The following is a description of a gene set: Mouse Gene Set: GOBP_PEROXISOME_FISSION species: Mus musculus The division of a mature peroxisome within a cell to form two or more separate peroxisome compartments., and this is the list of marker genes: Acox1, Acot8, Pex11b, Pex11a, Pex19, Pex11g, Sec16b, Dnm1l, Opa1, Fis1, Mff